Given this list of marker genes RNF207, KCNQ1, CAV1, MYH7, SMAD5, KCNE4, MYH6, KCNH2, KCNE1, TNNI3K, SCN5A, TNNI1, TNNC1, SCN3B, TMEM38A, DSC2, SCN3A, KCNA5, JUP, ABCC9, SCN11A, RYR2, VEGFB, MIR1-1, SCN1A, PIK3CA, AKAP9, UCN, SCN4A, TNNT2, P2RX4, CASQ2 (calsequestrin 2), CACNA1C, PDE4D, SGCD, CACNA1G (NCBI Gene Id 8913), KCNN2, NUP155, TPM1, ACTC1, SCN7A, MYL3, CSRP3, ATP1A2, ATP2A1, SCN9A, ADRA1B, MIR133A1, ADRA1A, SCN2B, RGS2, NKX2-5, GSTO1 (NCBI Gene Id 9446), TRDN (NCBI Gene Id 10345), JPH3, SCN10A, KCNJ8, FLNA, KCNE2, GATA4, SCN4B, FKBP1A, CAV3, BIN1, CACNA1D, C10orf71, GSN, SCN8A, NEDD4L, GJC1, SMAD7, GSTM2 (glutathione S-transferase mu 2), CAMK2D, KCNE3, FKBP1B, PPP1R13L, SRSF1, GJA5, PDE4B, SNTA1, SCN2A, CACNB2, TNNI2, HRC, NOS1AP, GPD1L, MYBPC3, MIR30E, DSP, CLIC2, ADORA1, SLC8A1, MIR328, PKP2, ATP1B1, MYH7B, TNNI3, KCNE5, MAP2K3, STRIT1, MYLK2, KCNJ2, ADCY10, CACNA2D1, FGF12, MYL4 (NCBI Gene Id 4635), CALM2, JPH4, PRKACA, JPH2, NPPA (natriuretic peptide A), CALM3, TTN, ATP2A2 (NCBI Gene Id 488), EHD3, SCN1B, DLG1, ACE2, PLN, TMEM38B, ZC3H12A, ANK2, SUMO1, SRI, ATP1A1, STC1, CALM1, KCNJ5, BMP10, TCAP, NOS1, GJA1, GAA, KCND3, ASPH, CHGA, KCNJ3, RANGRF (NCBI Gene Id 51536), MIR448, PIK3CG, HSP90AA1, TRPM4, HCN4, JPH1, DSG2, DMD, MYL2, FGF13, MTOR, MIR200C, GRK2, MAP2K6, CTNNA3, SLC9A1, here is a description of the gene set: Muscle contraction of cardiac muscle tissue. Human Gene Set: GOBP_CARDIAC_MUSCLE_CONTRACTION studied in species Homo sapiens